Given this list of marker genes FTL, ADGRG1, RPL34, APLP2, RPS3A, RPS5, TFPI2, SASH1, CCNI, SRP14, PABPC1, NORAD, YBX1, NPM1, RPL11, RPS16, PDIA3, SPP1, ASAH1, PCBP1, ODC1, RPL14, CD59, RPS9, DYNLT1, S100A6, HNRNPDL, ATP6V1G1, CYSTM1, HLA-A, PAPOLA, RPL21, RAN, MET, HSPA8, EHF, RPL10A, EDF1, HSPA9, DSP, TACSTD2 (tumor associated calcium signal transducer 2), RPS25, NDUFA4, PRPF40A, HLA-B, IFITM3, GAS5, HIPK2, RPS6, PRDX1, PSMA7, PPIB, CLTA, RPLP1, HNRNPM, CD24, DUSP6, JAK1, CRYAB, CALM1, UBB, RPS18, MAOA, RPS2, SLC34A2, EEF1B2, ENO1, SERF2, ANXA5, PLOD2, HNRNPA2B1, RPS19, EDIL3, NAMPT, NCL, RPS11, HSPA5, S100A10, RPL23, PGK1, TCIM, RPS23, SARAF, EIF4A2, LDHB, RPL15, TMF1, ARF1 (NCBI Gene Id 375), SRSF3, TNFSF10, PTGES3, HNRNPA3, SF3B1, NAP1L1, XRCC5, RPS12, MMP7, CTSB, FUBP1, RPL3, CTSL, CSDE1, HSP90AB1, SLPI, CANX, EEF1A1, SERPINA1, B2M (NCBI Gene Id 567), TPM1, CIB1, PEBP1, ACSL4, RPL13A, RPS27A, HINT1, TPM3, RTN4, RPS13, LRRK2 (NCBI Gene Id 399472), ADAMTS1, MYO9A, CLU, RPL37A, RPL9, MYL12B, GAPDH, TFPI, RPL6, CPE, RPL35, SEC62, PFKFB3, EID1, RPL19, GSTP1, IL6ST, EIF4G2, NFKBIZ, PTTG1IP, HNRNPU, UBXN4, RPL18, CAPN2, HSP90AA1, PKM, RPS20, RPS27, CCT6A, SOD2, RPL5, FOXP2, TGM2 (transglutaminase 2), UBE2D3, PGGHG, VMP1, EIF5, RPL13, ITGA2, CYP24A1, MYL12A, EPRS1, CEBPD, RPS15, RPL7, YWHAB, GDF15, IQGAP1 (IQ motif containing GTPase activating protein 1), ACTG1, DDX5, RPL4, TNFRSF11B, KRT18, CD9, KTN1, ADAM10, LMAN1, PTMA, KRT8, RPS8, LITAF, ALDOA, TXNIP, LAPTM4A, CNBP, TMSB10, RPL30, EIF1, ITGB6, RPS14, RPS7 (ribosomal protein S7), SERBP1, RPL10 (ribosomal protein L10), TMBIM6 (NCBI Gene Id 7009), NFE2L2 (NCBI Gene Id 4780), RPL8, HSP90B1, RACK1 (NCBI Gene Id 90938), CD63, UBA52, RPS17, PDIA6, ZFP36L1, BTG1, ITM2B, SOD1, PSMB1, FAU, ERMP1, RPL31 (NCBI Gene Id 6160), RPLP0, MT2A, TAF1D, ALDH1A2, EPCAM, PFDN5, ARHGAP29, SAT1, TIMP1, TSC22D1, CIRBP, VCAM1, LDHA, DSTN, EEF2, CD164, PPIA, RPS28, UGT2B7, H3-3B, RPS4X, RPL32, HNRNPR, NACA, ARHGAP5, BEX3, HNRNPC, SKP1, EGR1, HMGB1, MYL6, HSPD1, ATP5F1A, ANXA2, RPSA, RHOA, RPL7A, GNAS, VCL, CYB5A, ZNF770 (NCBI Gene Id 54989), TAX1BP1, BTF3 (basic transcription factor 3), RPL24, CHD1, SERPING1, GPX1, TPI1, RPL41, FTH1, PAX8, RPL12, ID1, TMEM59, LINC01320, PTBP3, RPS24, CDH6, HIF1A, RPLP2, IGFBP7, SLC38A1, CNDP2, PLEKHA1, KIF5B, TPT1, RASD1, REEP5, EEF1D, here is a description of the gene set: from publication Lake BB, Chen S, Hoshi M, Plongthongkum N, Salamon D, Knoten A, Vijayan A, Venkatesh R, Kim EH, Gao D, Gaut J, Zhang K, Jain S (PMID 31249312) species: Homo sapiens Human Gene Set: LAKE_ADULT_KIDNEY_C8_DECENDING_THIN_LIMB